The following is a description of a gene set: Human cytomegalovirus (HCMV) induces pro-inflammatory monocytes following infection and we have evidence that phosphatidylinositol 3-kinase is a key mediator in this activation. To begin to address how this signalling pathway is responsible for the functional changes in infected monocytes, we examined the role this pathway played in the transcriptome of infected monocytes. Global transcriptional profiling using cDNA microarrays revealed a significant number of genes were regulated in a PI(3)K-dependent manner, identifying this pathway as a key cellular control point in the conversion of monocytes to an activated pro-inflammatory state following HCMV infection. from publication Chan G, Nogalski MT, Bentz GL, Smith MS, Parmater A, Yurochko AD (PMID 20173022) Human Gene Set: GSE19772_HCMV_INFL_VS_HCMV_INF_MONOCYTES_AND_PI3K_INHIBITION_UP Genes up-regulated in monocytes after HCMV infection: untreated versus pre-treated with Ly294002. studied in species Homo sapiens, and this is the list of marker genes: CCDC93, MMP11, BZW2, BCL7B, TGFBR1, FBLN2, CLDN7, ZNF385A, POLR2L (NCBI Gene Id 5441), ADA, PNKD, TRAIP, CDH16, DHODH, MED27, BARX1, KRT81, GRB10, KLF13, GRK6, CD79A, CLCN7, TPO, EPX, HEMGN, MAFF, MCRIP1, KIF5A, GADD45B, GPR27, KLF1, NPPA, CNTROB, SLC4A4, TCF7L1, COL26A1, PDGFRB, ACY1, MIA, ACTA1, NR1H2, GGT1, CFP, KLF5, SLC22A6, RXRA, CD151, IL6R, TECTA, ELK4, SYT11, RBP1, CEBPA, IGFBPL1, PARM1, TARBP2, SEMA6D, ACTL6B, ADGRE5, INA, SEMA6B, TSPYL1, WNT5B, AFP (alpha fetoprotein), SERPIND1, FGF5, CELSR1, KHDC1L, RGS11, ORC1, SIM2, LCOR, LAMB1, SCMH1, DAB2IP, DPYSL4 (dihydropyrimidinase like 4), TMUB2, DCX, ADCYAP1R1, F2RL3, DSC1, DNTT, MYL4, RAMP2, SOCS3, LY6D, MYBL2, CD8B, FLT1, RPS25, PLXNB2, C3AR1, NHSL2, ERF, PKNOX1, PAX2, VDR, NAP1L4, SORD, CIC, GAMT, ARID3B, LMO2, C11orf16, POU3F1, CDSN, PAPOLA, MEF2B, PMEL, COP1, PKDCC, ADCY6, EXOSC8, WWTR1, GJA8, FAM220A, KRT17, ISLR, PDYN, CLEC4F, PTCRA, PRR15, HTR3A, HCN3, CMTM4, DLG3, CLEC11A, KCNJ11, RAB3A, SERPINA10, GDNF, TCP10L, KLKB1, GSTM3, XCR1, PTPRK, USP3, SIT1, IDS, PAX8, NOTCH1, AP5S1, TNNC2, OC90, TUBB6, F10, SLC22A4, ANXA3, F5, RSPO2, PIP5K1C, JUP, PRRC2A, LDB2, FASTKD5, EFNA2, GJB5 (NCBI Gene Id 2709), SLC6A3, SRCIN1, DRC1, PRKCZ, OAZ3, ZNF703, MST1, BMP1, SLC4A1, CCR7, ANGPTL2, TULP3, C1orf52, NCAPH, TRPC4, FMNL3, MCM6, SFRP2, RFLNB, EXO1, ATP5MC1, TSN, EIF3F, PLP1, SLC5A11, C8G (complement C8 gamma chain), SMPD2, EIF4EBP2, DDR2, EPAS1 (NCBI Gene Id 2034), CAMK2A, ARL4C, DNAJB5, CELA1, ANKRD11, SLC2A2, FGFR4, SLC16A2, RAD54L, CDS2, CD5L, IMMT, HS3ST3A1